The following is a description of a gene set: The process of protecting a cell from natural killer cell mediated cytotoxicity. studied in species Homo sapiens Human Gene Set: GOBP_PROTECTION_FROM_NATURAL_KILLER_CELL_MEDIATED_CYTOTOXICITY, and this is the list of marker genes: SERPINB9, HLA-B, HLA-G, HLA-A, SERPINB4, HLA-E